The following is a description of a gene set: A process in which a protein is transported to, or maintained in, a location within a non-motile cilium. species: Homo sapiens Human Gene Set: GOBP_PROTEIN_LOCALIZATION_TO_NON_MOTILE_CILIUM, and this is the list of marker genes: ROM1, ZDHHC3, BBIP1, ARL13A, TULP1, TUB, BBS4, PCARE, IFT80, GFY, ARL13B, TTC21B, SPATA7, ARL6, RPGR